The following is a description of a gene set: Human Gene Set: MIR610 from publication Chen Y, Wang X (PMID 31504780) species: Homo sapiens Genes predicted to be targets of miRBase v22 microRNA hsa-miR-610 in miRDB v6.0 with MirTarget v4 prediction scores > 80 (high confidence targets)., and this is the list of marker genes: NIPA2, LGALSL, LGI2, AQP9, GJA3, CIT, MMP24 (matrix metallopeptidase 24), PEA15, LIN54, KITLG, NLRP3, BTN3A1, ANKRD20A3P, FNDC3B (fibronectin type III domain containing 3B), CFAP68, TMEM33, ZBTB46, EBF1, PRF1, UBE2V1, HIBADH (NCBI Gene Id 221893), KRT1, SOX13, SLAIN1, RGS7, SESN3, NRIP3, TTC33, IPMK, USP33, BCL2L2-PABPN1 (NCBI Gene Id 100529063), ANKRD20A4P, RPS24, DET1, UBE2E3, ARL3, SLC37A2 (solute carrier family 37 member 2), PIP4K2B, ANKRD20A2P, AGK, PARPBP, LNPEP, UGDH, RPRD1A, DPH3, PUS7, MARVELD1, IL15, TMEM144, PABPN1, NUMBL, RORA, NKAIN2, RIMS4, RANBP3L, LYSMD3, EVI5, CIPC, CYBRD1, UBE2D1, SMARCC1, CENPA, PGGT1B, UNKL, NYAP2, PEDS1-UBE2V1, ANKRD20A1, FGF14, CREG2, MBOAT7, FEN1, TUB, PIP5KL1, E2F7, POLR3E, LMBR1, DTX4, NSUN5, RBL1, PAN3, RNF220, ODF2, PTPRD, BTN3A2